Given this list of marker genes DUSP2, NR4A1, FOSB, PLA2G6 (NCBI Gene Id 8398), GATA2, PPP1R15A, HSPA1A, TIPARP, FZD2, IER3, PTGES, KLF10, INSIG1, JUNB, PDE8B, EGR1, JUN, RGS16, TPTEP1, MNT, EXT1, KLF6, here is a description of the gene set: Genes modulated in HeLa cells (cervical carcinoma) by TNF not via NFKB pathway. Human Gene Set: TIAN_TNF_SIGNALING_NOT_VIA_NFKB studied in species Homo sapiens Tumor necrosis factor (TNF) is a pro-inflammatory cytokine that controls expression of inflammatory genetic networks. Although the nuclear factor-kappaB (NF-kappaB) pathway is crucial for mediating cellular TNF responses, the complete spectrum of NF-kappaB-dependent genes is unknown. In this study, we used a tetracycline-regulated cell line expressing an NF-kappaB inhibitor to systematically identify NF-kappaB-dependent genes. A microarray data set generated from a time course of TNF stimulation in the presence or absence of NF-kappaB signaling was analyzed. We identified 50 unique genes that were regulated by TNF (Pr(F)<0.001) and demonstrated a change in signal intensity of+/-3-fold relative to control. Of these, 28 were NF-kappaB-dependent, encoding proteins involved in diverse cellular activities. Quantitative real-time PCR assays of eight characterized NF-kappaB-dependent genes and five genes not previously known to be NF-kappaB-dependent (Gro-beta and-gamma, IkappaBepsilon, interleukin (IL)-7R, and Naf-1) were used to determine whether they were directly or indirectly NF-kappaB regulated. Expression of constitutively active enhanced green fluorescent.NF-kappaB/Rel A fusion protein transactivated all but IL-6 and IL-7R in the absence of TNF stimulation. Moreover, TNF strongly induced all genes in the absence of new protein synthesis. High probability NF-kappaB sites in novel genes were predicted by binding site analysis and confirmed by electrophoretic mobility shift assay. Chromatin immunoprecipitation assays show the endogenous IkappaBalpha/epsilon, Gro-beta/gamma, and Naf-1 promoters directly bound NF-kappaB/Rel A in TNF-stimulated cells. Together, these studies systematically identify the direct NF-kappaB-dependent gene network downstream of TNF signaling, extending our knowledge of biological processes regulated by this pathway. from publication Tian B, Nowak DE, Jamaluddin M, Wang S, Brasier AR (PMID 15722553)